The following is a description of a gene set: studied in species Homo sapiens Human Gene Set: FAN_EMBRYONIC_CTX_BIG_GROUPS_BRAIN_ENDOTHELIAL from publication Fan X, Dong J, Zhong S, Wei Y, Wu Q, Yan L, Yong J, Sun L, Wang X, Zhao Y, Wang W, Yan J, Wang X, Qiao J, Tang F (PMID 29867213), and this is the list of marker genes: SCARF1, TPM2, ITGB1, PAPSS2, VIM (NCBI Gene Id 7431), H2AJ, CA4, RGS5, IQGAP1, LAMC3, NR2F2, COL4A1, GPCPD1, CAST, RGS3, TFPI, PODXL, PLAC9, MCAM, PMP22, ZNF366, C1orf54, VWA1, PLCE1 (phospholipase C epsilon 1), AGRN, PLXND1, B2M, PECAM1, PPP1R14A, SRARP, PRCP, SLC40A1, SLC12A7, MYO6, GOLIM4, ANXA1, TESC, SLC12A2, ITIH5, THSD1, MAP4K2, SEMA5A, KCNJ8, LTBR, CLIC1, TES, ADA, TMEM109, PCDH12, FOXC1, EVA1B, ESYT2, SLC38A5, EMCN, HES1 (NCBI Gene Id 3280), GALNT18, APCDD1, LMO2, ACVRL1, ABLIM1, OAS2, ISG15, UACA, PGF, MYCT1, CYTH3, RHOJ, PDE8B, CERS2 (ceramide synthase 2), CD93, PHACTR2 (NCBI Gene Id 9749), DIPK2B, AEBP1, COL5A2, TACC1, CD248, BST2, RHOC, MYO1C, LGALS1, FOXS1, SLC6A12 (solute carrier family 6 member 12), NOSTRIN, ENG, LAMC1, SERPINH1, FOXF2, COL18A1, KANK2, FSTL1, KDR, NHERF1, PALD1, JAM2, PRELP, SELENOM, IFI6, APOLD1 (NCBI Gene Id 81575), PDZD2, CPD, CCDC3, COL6A1, DCN, ITM2A, IFITM3, PRXL2A, NOTCH4, ILK, CAPN2, IGFBP7, PROCR, RAPGEF4, FRZB, CGNL1, TM4SF18, CSPG4, STOM, CDH6, TFRC, TM4SF1, JAK1, GGT5, WWTR1, REEP3, SLC3A2, RGCC, IFITM2, TIE1, STING1, LEF1, TMEM204, CLDN5 (claudin 5), MYO1B, SPARC, ABCB1, SMTN, COL1A2 (collagen type I alpha 2 chain), TGM2, S100A10, SLC2A3, ID3, GIMAP7, PSMB8, SLC38A3, SLC39A8, EPAS1, CYB5A, MYL9, CAV1, PDXK, NR3C1, RHOA, FERMT2, TJP1, PLOD1, S100A16, ABCG2, SH2D3C, NID1, STARD13, COL6A2 (collagen type VI alpha 2 chain), SLC52A2, UTRN, ITGA1, NAMPT, ZIC2, FLI1, ISYNA1, PRKCH, ETS2, NOTCH1, PMEPA1, RBMS3, LAMB2, HSPA12B, DNAJC1, COBLL1, SLC7A8, CAVIN1, ETS1, CAVIN3, CLEC11A, MT1E, SAMM50, CLIC4, HLA-A, CYYR1, SLC39A10, MMP28, CNN2, CRIP2, SERTAD1, NHERF2, S100A13, BHLHE40, MGLL, CALD1, NID2, TMEM50B, FLT1, QPCT, TNS1, JCAD, RSU1, PARVA, HYAL2, TNFAIP8L1, DLC1, XAF1, ACTN1, TIMP1 (NCBI Gene Id 7076), CD82, PDGFRB (NCBI Gene Id 5159), TIMP3, EFEMP2, CD34, TUBB6, MSRB3, PON2, CETP, ATP1A2, CDH5, ID1, ITGA5, MFAP2, UNC5B, SLC16A1, MGST2, ECE1, PLXDC1, LAPTM4A, GJA4, PDE7B, PDLIM2 (PDZ and LIM domain 2), COLEC12, SNRK, CLEC14A, FKBP1A, IFI35, TSPAN9, IFI44L, POMP, ROBO4, MYLK2, TGFBR2, DPEP1, LY6E, EPSTI1, CLEC3B, CRIP1, VWF, IL32, SYPL1, ZEB1, COL4A2, ADGRL4, SIPA1, GNG11, DUSP6, FLNA, CAVIN2, COX7A1, EGFL7, ADGRF5, EBF1, EFNA1, EDNRA, LXN, STAT1, RNASE1, SLC7A1, EMP2, LAMA2, LAMA4, ECSCR, S1PR3, ERG, CYTOR, TAGLN2, CD9, SLC20A2, CDC42EP1, TTYH2, BSG, MT2A, VCL, IGFBP4, SLCO2A1, FKBP9, PTPRB (protein tyrosine phosphatase receptor type B), HLA-E (NCBI Gene Id 3133), KLF4, PPIC, NOTCH3, LMNA, GSDMD, NDUFA4L2, CDH11, SCARB1, MYL12A, WFS1, NKD2, HAPLN3, MECOM, IFITM1, DOCK6, JAG1 (jagged canonical Notch ligand 1), ECM1, BGN, FHL3, IFI27, AAMDC, SLC43A3, ANPEP, NECTIN2, MYH9, SLC2A1, CD320, ACTN4, GPER1, COL3A1, RAPGEF5, AFAP1L2, ARHGAP18, PXN, TCN2, STRA6, APLNR, FOXQ1, TMEM88, PDE8A, PDGFB, HEG1, GMDS, PLAT, SLC7A5, CA2, PCOLCE, SORBS3, SERPINB6, ESAM, HOPX, PELO, HLA-H, VAMP5, LHFPL6, HIGD1B, SERPING1, LAMB1, PCDH18, RELL1, TPM4, YES1, ADCY4, RAMP2, ARHGAP29, FN1, PCAT19, RRAS, CAV2, TGFB1I1, TEK, FXYD5, MFSD2A, RASGRP3